Given this list of marker genes Nup205, Cbx8, H4c11, H4c14, H4c17, H4c6 (NCBI Gene Id 319157), Nup133, H4c1, Scmh1, H4c8, Seh1l, Cbx4, Bmi1, Nup58, Nup155, Nup85, Nup42, H4c9, Rae1, Nup93, Ndc1, Ring1, Nup54, Cbx2, H4c18, Aaas, L3mbtl2, Nup210, H4c3, Hdac4, H4c12, H4c4, Sumo1, Satb2, Phc1, Pcgf2, H4c2, here is a description of the gene set: species: Mus musculus part of: SUMO E3 ligases SUMOylate target proteins Reactome Pathway: SUMOylation of chromatin organization proteins This event has been computationally inferred from an event that has been demonstrated in another species.<p>The inference is based on the homology mapping from PANTHER. Briefly, reactions for which all involved PhysicalEntities (in input, output and catalyst) have a mapped orthologue/paralogue (for complexes at least 75% of components must have a mapping) are inferred to the other species. electronically inferred by orthology from the curated human pathway